The following is a description of a gene set: Any process that activates or increases the frequency, rate, or extent of mast cell activation. species: Mus musculus Mouse Gene Set: GOBP_POSITIVE_REGULATION_OF_MAST_CELL_ACTIVATION, and this is the list of marker genes: Timd5, Tslp, Havcr1, Cftr, Timd6, Cd300lb, Crlf2, Nr4a3, Nectin2, Sphk2, Cd226, Timd2, Dppa1